Given this list of marker genes CAMK2N1, SPOCK1, NOL4 (nucleolar protein 4), ZNF486 (zinc finger protein 486), OSBPL8, NOVA1, ZNF737, SPTBN1, ABHD10, ZNF492, PPP3CB, TNFRSF11B, PLGLB1 (plasminogen like B1), UFL1 (NCBI Gene Id 23376), SLC10A7, RPGRIP1L, ZNF99, CADM2 (NCBI Gene Id 253559), SGCZ, ZEB2, FNDC3A, MANEA, SOCS4, CLASP2, GAB1, WNT5A, GLUD1, GTF2A1, GUCY1A1, MSH4, ZNF257, STEAP2, NEUROD1, FMO2, GDAP2, COBL, LHFPL2, OR2L13, CTNNB1 (catenin beta 1), GLYATL2, NDUFA12, CEACAM6, CYP2C9, MBNL3 (muscleblind like splicing regulator 3), NFYB, TLL1, KIF20B (NCBI Gene Id 9585), CASTOR2 (cytosolic arginine sensor for mTORC1 subunit 2), GLIPR1, SCN2A, WASHC4, STAM2, FABP4, FSTL5, NUDT4, CNTN3, LAPTM5, HSPA4L, TMEM41A, AMTN, SLC35A3, KCTD8, OPN3, GOLGA6L4, PKIB, AKIRIN1, ZNF716, ZNF493, ACOT13, CDK13, ZNF91, CLCN3, KANSL1L, CLU, B4GALT6, ZNF138, CIMIP6, TPST1, SRSF1, TET2, CDC27, FAM227B, KCTD9, HTR5A, CHIC1, PRLR, COMMD2, ZNF516, CDK6, INO80D, MBTD1, VCPIP1, ZFPM2, ZNF652, UBE3A, CSGALNACT2, ZNF626, PRB4, NFXL1, ZNF117, SLC2A13, SMG1, FZD4, CCDC91, PDE8A, CYP26B1, MBLAC2, SLC22A4, USP3, SCN3A, CDK18 (cyclin dependent kinase 18), ABI1, IFIT1, PECR, SPO11, LSM12, PRSS23, KCNC2, ENTPD7, TMPO, CEP350, ITM2B, PTBP3, RAB5B, PYGO1, CPNE8, CYP4V2, ASB7, EIF4G1, RAB3GAP2, AP1S3, MBIP, STK38L, SHC3, LAMA2, IL6ST, KIF3C, TERB2, TRPS1, FAM168A, AZIN1 (antizyme inhibitor 1), CAPZA2, UGT2B28, FUT9, PI15, ZNF90, PHF3, ANKRD29, ZNF519 (zinc finger protein 519, NCBI Gene Id 162655), PLG, EIF5A, B3GALT2, P2RY10, POLR1B, CFAP300, LPL (lipoprotein lipase), LRRTM3, DNAJA3, EDEM3, LACTB, TMEM126B, BMP3, PARP8, ZNF189, NCR3LG1, HNRNPC, RAB5C, VIP, ZNF28, CGGBP1, SLCO1A2, PHLPP2, HYDIN, WNK3, WDR11, PLGLB2, CERS6, SLC25A40, USP38, IGSF1, RALGPS2, PIK3C2G, HS3ST3B1, SYCP2, DIP2B, ERCC8, KLHL7, VTA1, ANKDD1A, MEX3A, AEBP2, THAP2, BEND4, TNFSF9 (NCBI Gene Id 8744), CCDC50, ZBTB20, USP32, ZNF506, JRKL, GRIP1, here is a description of the gene set: species: Homo sapiens Genes predicted to be targets of miRBase v22 microRNA hsa-miR-183-3p in miRDB v6.0 with MirTarget v4 prediction scores > 80 (high confidence targets). from publication Chen Y, Wang X (PMID 31504780) Human Gene Set: MIR183_3P